Given this list of marker genes SEMA3A, MSMB, E2F3, SATB1, NEO1, PRKD2, EDEM3, ADNP, TNNC1, NAB2, FOXN3 (NCBI Gene Id 654111), WAC, TMEM40, FAM13C, PI4KB, BCAS3, GLTP, SIK3, FOXF2, SKAP1, LTA, ARX, FGF9, GGA1, FEZF2, IL12B, ZCCHC14, CDKN2C, ARHGAP5, CDKN1A, TAOK1, PGAM2, CILP2, SLC9A6, UBR1, SLC10A2, HNRNPUL1, WDR53, TSC22D2, KLK8, DLG2, DUSP10, FIP1L1, TSPAN5, HIF1A, NPAT, RBM46, POLR2A (RNA polymerase II subunit A), PABIR1, UBE2E4P, FOXA2, TAL1, APP, EDA, ZBTB4, GMNN, CDC42EP3, UBE2Z, BTBD10, NCOA5, AMMECR1, EREG, EMX2, COL18A1, FYCO1, EEF1A2, EDC4, JARID2, BCL11B, ART5, NPPC, ZNF646, RO60, C12orf50, SP1, LRRC74A, NLGN2 (NCBI Gene Id 57555), CNTLN, ELAVL4, ATP6V0A4, SEPHS1, ZNF516-DT, PTGR3, TUBA8 (NCBI Gene Id 51807), CD68, PIK3R1, HMGCS1, PLCD3, C20orf204, SLC30A3, DEXI, MOSMO, OAZ3, GOLPH3L, KMT5C, GSE1, SEMA7A, PAX3, ARHGAP26, PER1, ATM, PABPC4, SPAG9, HENMT1, R3HDM1, SCN2A, ZNF654, JPH1, ATP2B3, SKIDA1, LANCL3 (NCBI Gene Id 347404), CHCT1, KITLG, CLUH, EFNA5, USP2, NRF1, GMPPB, CEP95, TFDP2, FXYD5, UCHL5, ETV6, TMIE, PHF13, PLPP1, CPNE1, SCGN, PCDH9, ARK2N, TTC9C, ESRRG, BCAM, MNAT1, STAG2, GRIK1, TET2, SAT1, KLF3-AS1, SIDT2, PRRC2C, CLK4, TPP2, TYRO3, MTIF2, AP5B1, GPR87, TMEM150A, MRGPRF, RANGAP1, FZD1, LINC03122, MGAT4C, CPZ, KLF3, HNRNPL, PTGFRN, PAX6, PRDM12, DDX5, ZNF541, PTCHD1, CPEB4, ALKBH5, MCTP1, RBMS2, FOS, GAREM1, ZBTB40, SP4 (Sp4 transcription factor), INTS7, MTSS1, CLEC18C, PHF21A, MED13, SCNN1A, ZMYM2, PCDH10, HOXB7, GATA6, PLK1, SRGAP2, MUC15, FGFBP3, TSC22D4, NDUFA4L2, CLPX, STIMATE, DUSP8, CACNA1C, FERRY3, CCL20, HTN1, PIP4K2B, EPHA7, MEF2A, ITPKC, FAM117A, DLG1, RAD51AP1, HOXA4, TBX3, TEF, ADRA2C, DPM3 (dolichyl-phosphate mannosyltransferase subunit 3, regulatory), GPX1, MARK2, COL15A1, TLE3, NECAP1, TRIB1, CDYL, C2CD4A, PLS1, ZER1, PPP2R5D, PITX2, SOST (sclerostin), PRPF40B, PLEC, LRRTM4, TGIF1, EDN1, BMP10, FRMPD1, FOXG1, KIAA1549L, STARD7, PACSIN3, RHOD, FGF13, EPN1, PRUNE1, TRIM33, NRXN3, LRRN4CL, GRIA3, CELF4, ZNF367, BHLHE41, PIK3CD, MCPH1, HOXC4, TGFB3, CENPF, NAP1L5, OVOL2, RTL9, HOXA11, MEIS2, ZNF668, HS6ST3, UXT, KMT2E, ACVR2A, ZPBP2, RBBP8NL, KIF3C, BLCAP, TLK1, LMO4, ARF6, PRDX2, PPARG, ALG10, BEND6, ADCY8, POLA2, LRGUK, HOXC6, ACIN1, here is a description of the gene set: studied in species Homo sapiens Genes having at least one occurrence of the motif GKCRGKTT in the regions spanning 4 kb centered on their transcription starting sites. This matches the TCF1 transcription factor binding site V$TCF1P_Q6 (v7.4 TRANSFAC). Human Gene Set: TCF1P_Q6